The following is a description of a gene set: Genes in the cancer module 9. studied in species Homo sapiens Human Gene Set: MODULE_9, and this is the list of marker genes: GRB2, HOOK1, TBX5, TXNDC12, DDA1, NOTCH1, SCAPER, ZNF408, NRP1, VIL1, ZNF175, DENND3, NFATC4, ARHGAP45, NCF2, VWF, ROBO1, N6AMT1, GSN, ANKRD26, DDX39B, STAR, SFTPD, FEZ2 (fasciculation and elongation protein zeta 2), FSTL4, TMA7, CELA3A, GLT8D2 (NCBI Gene Id 83468), STK25, PLA2G12B, KIF3B, TRAPPC6A, RFX7, TBL3, KCNA4, TSPAN8, AKT1, BCAS1, HTR2B, FAM234B, AQP2, SNX8, PLXDC2, HRAS, RBM17, DNAJC28, PER1, TINCR, IRF4, CDX1, ZNF195, TFPI, LRRC37A, CA4, ICMT, TNNT1, AHSG, SOX1, HSPB2, TERT, ACTN1, PRRG3, SYN1, CYP2A7P1, GIT2, ZNF79, ADORA1, H4C3, TTI1, CD99L2, SYNGAP1, DHRS3, DNAJC10, AK1, SLC16A4, CCHCR1, CECR2, GINS3, PLCD1, PSCA, KCNJ4, EIF4EBP1, DMWD, MRPS31, EGF, ASAP3 (ArfGAP with SH3 domain, ankyrin repeat and PH domain 3), VAMP5, ZNF214, ORC6, RBMS1, PABPC3, NAT8, ETAA1, HAS2, TOX4, BCAP29, TMEM30A, MAPK9, GPC5, NTRK3, EDN2 (endothelin 2), TEX14, TIRAP, ARSB, VPS45, MAP1A, TMEM40, LGMN, RHOT1, OPHN1, ZYG11B, HSPA8, CDC14A, POPDC2, FBXL5, ZNF624, ENTREP1, SCARA3, ZNF211, ID2B, IL33, TMEM231, METTL16 (NCBI Gene Id 79066), CNBD2